The following is a description of a gene set: species: Homo sapiens part of: TRIF (TICAM1)-mediated TLR4 signaling  Cell stimulation with viral double-stranded (ds) RNA and bacterial lipopolysaccharide (LPS) activate Toll-like receptors 3 (TLR3) and TLR4, respectively, triggering the activation the activation of two IKK-related serine/threonine kinases, TANK-binding kinase 1 (TBK1) and IκB kinase ε (IKKε, IKBKE) which directly phosphorylate interferon regulatory factor 3 (IRF3) and IRF7 promoting their dimerization and translocation into the nucleus. Although both kinases show structural and functional similarities, it seems that TBK1 and IKBKE differ in their regulation of downstream signaling events of TLR3/TLR4. <p>IRF3 activation and interferon β (IFNβ) production by poly(I:C), a synthetic analog of dsRNA, are decreased in TBK1-deficient mouse fibroblasts, whereas normal activation was observed in the IKBKE-deficient fibroblasts. However, in double-deficient mouse fibroblasts, the activation of IRF3 is completely abolished, suggesting a partially redundant functions of TBK1 and IKKε (IKBKE) (Hemmi H et al., 2004). <p>The poly(I:C)-induced phosphorylation of TBK1 and IRF3 was abolished in TRIF (TICAM1)-knockout human keratinocyte HACAT cells (Bakshi S et al., 2017). TICAM1 is utilized as an adaptor protein by TLR3 and TLR4 (Yamamoto M et al., 2003). <p>TLR3 recruits and activates PI3 kinase (PI3K), which activates the downstream kinase, Akt, leading to full phosphorylation and activation of IRF3 (Sarkar SN et al., 2004). When PI3K is not recruited to TLR3 or its activity is blocked, IRF3 is only partially phosphorylated and fails to bind the promoter of the target gene (Sarkar SN et al., 2004). Reactome Pathway: Activation of IRF3, IRF7 mediated by TBK1, IKKε (IKBKE), and this is the list of marker genes: TANK, OPTN, UBB, TICAM2, IRF7, IRF3, TRAF3, PTPN11 (NCBI Gene Id 84990), TLR4, TICAM1, UBC (NCBI Gene Id 7316), RPS27A, TBK1, IKBKE, SARM1, UBA52, LY96, CD14